The following is a description of a gene set: Mouse Gene Set: chr3G3 studied in species Mus musculus, and this is the list of marker genes: Gm40155, Arhgef38, Gm29811, Tacr3, Gm19148, Npnt, Metap1, Gm5105, Gimd1, Cenpe, Gm6077, Gm35986, 4930539C22Rik, Sgms2, Gm26820, Cisd2, Trmt10a, 4930579F01Rik, Lrit3, Gstcd, Cyp2u1, Gm18546, 4930539J05Rik (RIKEN cDNA 4930539J05 gene), Gm16559, Slc9b2, Pla2g12a, Gm23467, Papss1, Lef1, Sec24b, Gm40153, Bank1, Gm4860, Ostc, 5830437K03Rik, Adh6-ps1, A430072C10Rik, 1700030L20Rik, Ddit4l, Oaz2-ps (ornithine decarboxylase antizyme 2, pseudogene), Slc39a8, Ube2d3, Dnajb14, Mir6380, Casp6, Gm23011, Pitx2, Mcub, Aimp1, Tbck, Gm43403, Gm5281, Slc9b1, Dapp1, Eif4e, Gar1, Gm9387, Nfkb1, Cxxc4, Mir1895, Gm23196, Mir1956, Gm43116, Rpl34, Tet2, Adh6a, Gm31243, Gm4861, Gm25080, Gm567, Gm36520, Enpep, Gm26691, 1110002E22Rik (RIKEN cDNA 1110002E22 gene), Manba, Ppp3ca, Gm42650, 4930534D22Rik, 4930599N24Rik, Gm30648, 2810428J06Rik, Gm43522, Emcn, Gm31678, Gm9402, Col25a1, Gm9403, Adh6b, Bdh2, Gm9409, Ints12, Gm5982, Gm30946, Adh1, Gm30484 (NCBI Gene Id 102632401), Gm43351, Gm15460, Adh5, Etnppl, Egf, Dkk2, 2010110G14Rik, Rpl7a-ps7, Gm4410, Mttp, Elovl6, Gm18330, Gm49316, 0610031O16Rik, Gm9397, Gm2142, Ppa2, Pou5f1-rs4, Gm29865, 4933401H06Rik, Adh4, Gm5855, Hadh, Gm43357, Olfr375-ps1, Gm18492, H2az1, Cfi, Rrh, Gm22322, Lamtor3, Gm9396, Gm19708, Gm9408, Adh7